The following is a description of a gene set: studied in species Homo sapiens Human Gene Set: HP_CHORIORETINAL_DYSPLASIA Chorioretinal dysplasia Abnormal development of the choroid and retina., and this is the list of marker genes: FKTN, B3GALNT2, TUBGCP4, DAG1, RXYLT1, POMK, POMT1, KIF11, COL4A1 (collagen type IV alpha 1 chain), OCRL, POMGNT2, HCCS, TUBGCP6, B4GAT1, CRPPA, NDUFB11 (NADH:ubiquinone oxidoreductase subunit B11), COX7B, LARGE1, POMGNT1, FKRP, POMT2